Given this list of marker genes cpnT, here is a description of the gene set: studied in species Homo sapiens Reactome Pathway: Escape of Mtb from the phagocyte part of: Infection with Mycobacterium tuberculosis The roughly constant numbers of Mycobacterium tuberculosis (Mtb) during the chronic phase of infection are due to a balance between rapid replication and death. The relatively safe environment for Mtb in the phagocyte's phagosome is overcome when about 20-25 bacterial cells accumulate. First, the phagosomal membrane is destroyed. Then, by injuring mitochondria and depleting NAD+, cell necrosis is started, resulting in Mtb escape.